Given this list of marker genes CHCHD4, RAB8A, JKAMP, THEMIS2, GLE1, IFI30, RNF44, TLR1, PIP5K1C, FHOD1 (NCBI Gene Id 29109), SP1, ELOVL1, TNFAIP8L2, NLRP12, TPRG1L, TACC1, PCBP1, ISCA2, DUSP18, BAG4, SLC31A2, PLXNB2, CXCL16, CENPBD1P, FAM89B, TMEM43, PPP1R8, TMEM9B, CHAMP1, RNF34, GIT2, SMC3, ARRDC2, OSBPL11, DCAF12, WBP1L, CASP2, RICTOR, MAP3K14, YY1, PLEKHO2, MRM2 (NCBI Gene Id 29960), PSMG2, SDHAP1, TOR1A, PHAF1, ASB7, PAFAH1B2, KIAA2013, RAP2B, VPS35, CBL, FAM78A, NAP1L4, DCAF7, ORAI2, SASH3, USP3 (NCBI Gene Id 9960), PIGM, KANSL1, SETD1B, ZNF226, AGGF1, ZNF227, DPP8, GABARAP, KLF13, SNX17, PXN, SF3B2, ITPRIPL2, FRAT2, SRSF9, TGFBR2, FBXO7, DCAF5, ARPC1B, ZNF45, PTP4A2, CTDSP1, TMEM248, TNFAIP8L1, NLRC4, TLE3, GDE1, ARAP3, DSTYK (dual serine/threonine and tyrosine protein kinase), LASP1, FRAT1, CSF1R, HINFP, LRRC47, DNAJC5, TRIM38, MNT, MBD2, BRD8, USP4, GIMAP8, ENC1, RUNDC1, UBE2Q2, QRICH1, CXCR4, CALHM2, CNBP (CCHC-type zinc finger nucleic acid binding protein), PUM2, PURA, TSC22D3, ORC5, CRBN, NRBP1, RNF220, PAGR1, RETREG3, CTDSP2, TCF20, PGP, MEAF6, ORAI3, ACVR1B (NCBI Gene Id 93351), WDR82, BMF, IFFO1, TRAPPC12, WIPI2, HECA, PRR13, ZBTB44, TFEB, RALA, TAF5, PRELID1, ARHGAP30, TMEM250, CMTM3, NUP214, HHEX, ATXN2 (ataxin 2), ZNF747, UBALD2, ZNF282, NUP50, ZNF555, RTF1, BRI3, MSRB1, NELFB, CSK, NCOA6, STX6, PHC2, RNF38, ATG9A, DOK2, TMEM121B, RAB11FIP4, BRPF1, ZNF398, ZNF432, HARS2, DDX17, FOXK1, GRN, THAP11, CASP8, CAB39, ZFP36L2, OLIG1, USP22, ARL6IP5, SYNRG, DUSP7, PHF23, KLHDC3, MKRN1, RGS19 (NCBI Gene Id 10287), KDM2B, DAGLB, CTCF, POLDIP3, B4GALT7, PLEKHO1, CHD8, CCR2, MAP7D1, CRTC3, UBAC1, STAU1, SH2D3C (NCBI Gene Id 10044), ZDHHC7, DDX23, KDM3B, RCOR3, TBC1D10B, APOBR, MARF1, KDM3A, DNAJC13, WASF2 (NCBI Gene Id 10163), here is a description of the gene set: TREM-1 is an orphan immunoreceptor expressed on monocytes, macrophages, and neutrophils. TREM-1 associates with and signals via the adapter protein DAP12/TYROBP, which contains an immunoreceptor tyrosine-based activation motif (ITAM). TREM-1 activation by receptor cross-linking is pro-inflammatory, and can amplify cellular responses to Toll-like receptor (TLR) ligands such as bacterial lipopolysaccharide (LPS). To investigate the cellular consequences of TREM-1 activation, we have characterized global gene expression changes in human monocytes in response to TREM-1 cross-linking in comparison to and combined with LPS. Both TREM-1 activation and LPS up-regulate chemokines, cytokines, matrix metalloproteases, and PTGS/COX2, consistent with a core inflammatory response. However, other immunomodulatory factors are selectively induced, including SPP1 and CSF1 (i.e., M-CSF) by TREM-1 activation and IL-23 and CSF3 (i.e., G-CSF) by LPS. Additionally, cross-talk between TREM-1 activation and LPS occurs on multiple levels. While synergy in GM-CSF protein production is reflected in commensurate mRNA abundance, comparable synergy in IL-1b protein production is not. TREM-1 activation also attenuates the induction of some LPS target genes, including those that encode IL-12 cytokine family subunits. Whereas positive TREM-1 outputs are abolished by the PI3K inhibitor wortmannin, this attenuation is largely PI3K-independent. These experiments provide a detailed analysis of the cellular consequences of TREM-1 activation, and highlight some of the complexity in signal integration between ITAM- and TLR-mediated signaling. Genes down-regulated in comparison of monocytes treated with 1 ng/ml LPS (TLR4 agonist) versus monocytes treated with control IgG. from publication Dower K, Ellis DK, Saraf K, Jelinsky SA, Lin LL (PMID 18292579) Human Gene Set: GSE9988_LOW_LPS_VS_CTRL_TREATED_MONOCYTE_DN studied in species Homo sapiens